The following is a description of a gene set: studied in species Mus musculus Mouse Gene Set: chr10D2, and this is the list of marker genes: Gm19090, Gm10741, Il22, 4930471E19Rik, Gm10747, Gm4065, Gm4129, Gm3942, 5330439M10Rik, Limk1-ps2, Dyrk2, Kcnc2, Gm6808, Myrfl, Cdc5lrt9, Gm40810 (NCBI Gene Id 105245337), Frs2, Gm18904, Atxn7l3b (NCBI Gene Id 76122), Lyz2 (NCBI Gene Id 17107), Mon2, Caps2, Gm32235, Cdc5lrt1, Mirlet7i, Il22b, Gm16166, A430028G04Rik, D930020B18Rik, Cpsf6, Rxylt1, Nup107, Gm26596, Gm9002, Slc35e3, Gm32552, Gm4478, Sros1, Lrrc10, Kcnmb4os2, Gm36208, Srgap1, 5330438D12Rik, Mdm2, Tbk1 (NCBI Gene Id 80470), Rassf3, Tafa2, Gm10743, Ptprr, A130012E19Rik, Gm24298, Tspan8, Gm46204, Gm47425, Zfc3h1, Gm26579, Rab21, 1700010J16Rik (NCBI Gene Id 69355), Cdc5lrt8, Gm7269, Tmbim4, Lyz3, 4930423D24Rik, 4930503E24Rik, Gm31182, Glipr1l2, Tbc1d30, Gm48826, Glipr1l3, Usp15, Llph, Gm38403, Glipr1, Gm34045, Gm35404, Gm46203, Gm40778, Mdm1, Gm9081, Rab3ip, 4921513I03Rik, Ppm1h, Gm18510, Rap1b, Gm19169 (NCBI Gene Id 100418378), Cdc5lrt7, Tbc1d15 (NCBI Gene Id 66687), Kifc5c-ps, Mir6412, Ptprb, Cdc5lrt3-ps, Gm32141, Mir8104, 1700064J06Rik, Grip1os1, Grip1, Cand1, Cdc5lrt10, Gm32365, Gm9004 (NCBI Gene Id 668149), Gm8942, Gm22507, Gm15910, Gm8960, D630033A02Rik, 9230105E05Rik, 4932442E05Rik, 4933411E08Rik (RIKEN cDNA 4933411E08 gene), Gm40770, Cdc5lrt5, Kcnmb4os1, Tmem19, Gm10744, Irak3, Cdc5lrt4, Gm36041, 4930432O09Rik, Glipr1l1, Gm22958, Limk1-ps1, Mir763, Gm31267, Helb, Gm26976, Cdc5lrt6, Xpot, Lemd3, Gm47342, Lgr5, 4930477N07Rik, Avpr1a, 4933412E12Rik, Cpm (NCBI Gene Id 70574), Trhde, Gm33337, Ifngas1, Gm26495, Gm4489, Gm5781, Gm40787, Cnot2, Kics2, Gm18730, Ifng, 1700006J14Rik, Gm40773, Yeats4, Gm35865, Wif1, Thap2, A930009A15Rik, Gm15723, Lyz1, Cdc5lrt2-ps, Gns, Kcnmb4, Gm40765, 1700030O20Rik, Cct2, Msrb3, 4930473D10Rik, Krr1, Grip1os2, Gm10752, 4930579P08Rik, Gm33677, 4930422I22Rik, Tph2, Best3, Gm4473, 1700025F24Rik, Hmga2